Given this list of marker genes MESP2, MITF, TMEM270, COL3A1, SLC2A10, TAOK1, CCND1, BMPR2, PPP1CB, SOS2, PIGN, PKD1L1, SMAD4, TMEM260, MGP, RSPH9, SMC1A, BRD4 (NCBI Gene Id 90616), RIPPLY2, DLL3, MED12, DHCR24, NEK10 (NIMA related kinase 10), FADD, NIPA1, LRRC56, CCNO (cyclin O), KDM6A, EIF4H, DGCR6, FOXC2, CRELD1, RSPH1 (radial spoke head component 1), DNAH5, WNT3, DGCR2, CCNQ, GDF1, DEPDC5, B3GLCT, LIMK1, IFT56, ZMYND10, CLIP2, ADAMTS19, ZEB2, DNAAF11, ACVRL1, SOS1, SMG8, RPS15A, WNT4, CBL, PIK3CA, ARSL, SPEF2, DNAJC30, ELN, DNAI1, DVL3, TRAF7, SNAI2, NIPA2, NCF1, COL5A1, FBN1, MLXIPL, RSPH3, AGGF1, CCDC40, NKX2-5, POLR1A, DNAAF2, BCOR, SNX10, DRC1, TMEM94, BUD23, SOX10, TYR, TRAIP, CAPNS1, GDF2, FLT4, MYH7 (myosin heavy chain 7), KRAS, MYRF, MEG3, ODAD2, ALDH18A1, SKIC3, ODAD4, EFEMP2, DNAH11, TGFBR2, PIGL, STK36, BGN, DOCK6, NRAS, BCL11B, GATA6, CEP295, TCIRG1, TBX1, ODAD1, TTC12, POLA1, FOXJ1, HES7, RAF1, LTBP1, DNAAF5, NME5, GAS2L2, RERE, PAX6, NOTCH1, ITPR1, DNAAF4, TGFBR1, GTF2IRD1, TNFSF11, CITED2, CHD7, GATA4, RSPO2, STRA6, METTL27, CRTAP, RFC2, CDC42, ARHGAP31, GTF2IRD2, GPC3, LMNA, CNTN1, SMARCA4, ENG, FRA10AC1, RSPH4A, GPC4, KITLG, LFNG, DLL4, PTPN11, OTUD5, SPAG1, SPRED2, PLXND1, UBE2A, RBPJ, DNAH9, SKIC2, DLK1, CFAP74, ODAD3, NODAL, DNAAF3, MRAS, NAA10, NKX2-6 (NCBI Gene Id 137814), ZIC3, CIROP, DNAJB13, PORCN, JAG1, CFAP298, VPS37D, CAV1, VHL, WRN, PLD1, EOGT, TLL1, RRAS, LZTR1, ACVR2B, CCDC22, LTBP4, HYDIN, CFAP221, CFAP300, NOTCH2, ALDH1A2, AASS, RTL1, AFF4, IFT43, RPGR, SMAD2, FBLN5, FKBP6, SFTPB, BRAF, GPC6, CLCN7, DNAAF1, KMT2D, EIF2AK4, LIFR, DGCR8, OFD1, CCDC39, WT1, STX1A, TUBG1, FOXF1, CFAP53, DNAL1, TBL2, GTF2I, MMP21 (NCBI Gene Id 118856), ESS2, DAW1, NME8, ACTA2 (actin alpha 2, smooth muscle), ESAM, MCIDAS, EDNRB, RRAS2, BAZ1B, RPL10, IPO8, TBX5, FGFR1, RASA2, PIGO, DNAH1, DNAI2, DNAAF6, RIT1, here is a description of the gene set: Human Gene Set: HP_ABNORMALITY_OF_THE_PULMONARY_VASCULATURE Abnormality of the pulmonary vasculature studied in species Homo sapiens